The following is a description of a gene set: Human Gene Set: MIR6852_3P from publication Chen Y, Wang X (PMID 31504780) species: Homo sapiens Genes predicted to be targets of miRBase v22 microRNA hsa-miR-6852-3p in miRDB v6.0 with MirTarget v4 prediction scores > 80 (high confidence targets)., and this is the list of marker genes: MXI1, GRIA4, ZBTB1, SOX5, CD300E, TIMM23, PTGFRN, EDARADD, PRKG1, RAVER2, NAPEPLD, KCNA6, PRKG2, DNAJC15, TM9SF3, RING1, KLHL18, MAPRE1, YBX3, RGS3, CACUL1, MSTO1, AAK1, NBPF9, RPRD1A (NCBI Gene Id 55197), COBL, MMP25, DYNLT5, HAND2, MYCN, SCUBE3, MYL9, GHR, HCFC1R1, NFIX, NHS, GJB2, TAB3, MUC15, ONECUT2, TP53BP2, FZD10, RAB36, CETN1, MYO10, ACOT13, NOG, FCRL4, ADAMTS14, CYP7A1, SUMO3, OAS1, ZNF343 (NCBI Gene Id 93666), TRIP11, ZNF83, DHX15, ARID5B, GSK3B, SLC39A8, GASK1A, YBX2, RPP30, SLC24A2, DDR1, CASKIN2, RHBDL2, ZNF677, MYORG, PAX9, XPR1, FAM124B, CLUAP1, BTBD3, VIRMA, ASB1 (NCBI Gene Id 51665), CSMD1, ARIH1, TSC22D1, PBX2, NBPF11, NBPF1, CXADR, SAMD5, EP300, VSX1, WDR55, TMEM26, PGAP1 (NCBI Gene Id 80055), AQR, RBM25, HAUS6, FAM171A1, LMTK2, TMEM98, MYO7A, C14orf132, CBR4, AQP9 (NCBI Gene Id 366), KCNH5, CNOT6, CAAP1, SHANK2 (SH3 and multiple ankyrin repeat domains 2), ATXN7, NPR3, PLXNA2 (NCBI Gene Id 80253), SPOCK1, HAPSTR1, SUGP2, ASB13, NBPF15, ZNF337, NBPF8, PDZD2, NTAQ1, RBMS2, TTC14, PRDM7, PDE1A, FOXP4, MASTL, USP14, MEF2C, NBPF20, SPICE1, PTK7, FAM120C, KIF5B, CSNK1G1, CCND3, SLITRK4, USP19, SCML1, RSPRY1, ZNF589, CHM, MRI1, SH3D19, HEG1 (heart development protein with EGF like domains 1), ATP8A1, DERL2, SDK1, DAAM1, NBPF12 (NCBI Gene Id 440675), NUGGC, CLOCK, SLC6A20, CCNT1, SLC1A5, ADORA2B, BTN3A2, ZNF544, ZMYND8, PPP6R3, PDIA3